Given this list of marker genes PGM1, ALG12, ALG8, SRD5A3, AHCY, F7, SLC37A4, B4GALT1, ALG9, DPAGT1, GGCX, SERPINC1, ALG6, MPI, DPM2, PMM2, VKORC1, DPM1, STX5, MGAT2, here is a description of the gene set: An abnormality of the extrinsic pathway (also known as the tissue factor pathway) of the coagulation cascade. studied in species Homo sapiens Abnormality of the extrinsic pathway Human Gene Set: HP_ABNORMALITY_OF_THE_EXTRINSIC_PATHWAY